Given this list of marker genes Dcxr, Cryl1, Akr1a1, Xylb, Ugt1a6a, Sord, here is a description of the gene set: Mouse Gene Set: GOBP_URONIC_ACID_METABOLIC_PROCESS species: Mus musculus The chemical reactions and pathways involving uronic acid, any monocarboxylic acid formally derived by oxidizing to a carboxyl group the terminal hydroxymethylene group of either an aldose with four or more carbon atoms in the molecule, or of any glycoside derived from such an aldose.